The following is a description of a gene set: species: Homo sapiens The specification of the anterior/posterior axis of the embryo by products of genes expressed in the zygote; exemplified in insects by the gap genes, pair rule genes and segment polarity gene cascade. Human Gene Set: GOBP_ZYGOTIC_DETERMINATION_OF_ANTERIOR_POSTERIOR_AXIS_EMBRYO, and this is the list of marker genes: DCANP1, TIFAB, WT1, NEUROG1, PCSK6, BASP1, NCKAP1